The following is a description of a gene set: Human Gene Set: NKX2_3_TARGET_GENES Genes containing one or more binding sites for (NKX2-3) in their promoter regions (TSS -1000,+100 bp) as identified by GTRD version 20.06 ChIP-seq harmonization. from publication Yevshin I, Sharipov R, Kolmykov S, Kondrakhin Y, Kolpakov F (PMID 30445619) species: Homo sapiens, and this is the list of marker genes: EXOSC8, IRAK4, MIR5700, ATP5F1B, IFT88, FAM187A, NPAS1, RPS18, NQO2, RPRD2, BBIP1, WDR6, RNF26, ZNF462, TPP1, PGBD4, GRHL2, RNU11, MIDEAS, SNHG17, GFM2, KIF18A, EXD1, CAB39L, ARL3, C11orf54, TMEM106C, VANGL1, NAT9, LRRC49, POU6F1, RECQL, TSPAN4, CHMP2B, IFT56, R3HDM1, HSPG2 (NCBI Gene Id 7796), TINF2, MIR5579 (microRNA 5579), ORMDL2, HMGA2, SLC3A2, COX5B, MPI, HTT, SH3PXD2A-AS1, PIM1, DDIT3, ZFAND2A, RPL15, BRD2, NRDC, GALE, RAD52, TBC1D23, YOD1, NIPSNAP2, MAP2K3, AGPAT3, PTPA, NT5DC2, PSME2, INTS2, CLDN7, ACTG1, AVEN, PNPLA8, SERINC1, PDLIM2, MRPL42, SNORA57, MTPN, EFTUD2, CALM1 (calmodulin 1), YAP1, DCTPP1, COQ8B, EIF5-DT, TMT1B (thiol methyltransferase 1B), NUDCD3, KLRG1, AK1, BTN2A2, GPRC5B, FBXO24, PPIP5K2, SCARB2, ST3GAL3, CSKMT, SEMA5A, HTRA2, OXA1L, ZNF587B (zinc finger protein 587B), SCARB1, TMEM135, DNAJB9, PAK6, ACTR3C, IK, RPL7L1, NRM, SUGP2, TAFA2, CHP1, HLA-DMA (NCBI Gene Id 3108), MIR4645, ABCC3, PPFIA3, COPS7A, BNIP1, ANAPC5, CDC42SE1, TMEM67, ADGRE2, THAP5 (THAP domain containing 5), NIF3L1, APLP1, IFT74-AS1, NR1D1 (NCBI Gene Id 9572), EPS8, RCAN3, PIH1D1, TOMM40 (NCBI Gene Id 10452), CACNA1A, THUMPD3-AS1, DUS3L, ANO6, RIC8B, LINC02369, ZBTB7C, MRPL42P1, MBD5, RNF121, LINC02345, EMC7, EML4, PLEC, NUFIP2 (NCBI Gene Id 57532), TMEM253, ARSA, ITPRID2-DT, PLXNB1, RPAIN, SNORD59A, MRPS35, APPBP2-DT, FAM43A, RAG1 (recombination activating 1), TPM1-AS, SEC31A, ASIC1, MIR6165, TP53BP1, PEX12, ANO2, GRINA, RBCK1, TBRG4, KRTAP3-1, METTL15, TTC12, NDUFA2, C11orf98, PPP1R12A, MCFD2, ENSG00000261335, RBFOX2, ALG5, RPL26L1, CNTNAP1, MMP14, VPS16, ACP2, CNOT4, CAV1, HIF1AN, ACTR3 (actin related protein 3), DPPA5 (developmental pluripotency associated 5), AUP1, EDRF1, LEKR1, CDC37, BBX, USP8, MTMR4, SNORD49B, FAM221B (family with sequence similarity 221 member B), BUD31, NKD2, MED15, WBP11, LSM1, COPZ1, LINC-ROR, SNORD27, GRHL2-DT, SP1, RAMAC, SLAIN2, PTPN23, SUB1, COX18, TMEM8B, ANTXR2, GAPDH-DT, NPHS1, USP48, QRSL1, RPL26L1-AS1, TMTC2, LRIG2-DT, GDF11, PODNL1, ZHX2, FYN, MIR1293, ZGRF1, MRPL52, USP15, MEST, CASP6, EIF2S1, SNX1, IVD, ZNF862, FRS2, NARS2, EBNA1BP2, PDCD11, RAPGEF3 (NCBI Gene Id 27105), SULT1C2P2, UBE2F-SCLY, TOMM7, RPL37, RBPMS, TBX3, CCT6A, CCDC86, RBM3, LDLR, RHBDF1, CPSF7, UMAD1, ENSG00000224090, PTPRF, HOXA10-AS, SLC39A8, UACA, RBM19, KRT8, TRIOBP, HSPE1P12, BZW1-AS1, CASC11, SARNP (SAP domain containing ribonucleoprotein), MTIF2, LNPK, PHF19, FGD6, STK36, MFSD5, SIX5, SMU1, IST1, ACADSB, ATP6V1D, PFKFB2, MRPL33, CALM2, DGKE, SLC12A6, SRCIN1, SNORD25, TIA1, RBM7, NCOR2, ORC4, NBR1, ARFGEF2, SEPHS1P7, GFAP, HILPDA-AS1, RPA3, TPM1, PPP3CA, PPCDC, ZNF546, CHCHD5, SLC7A7, PPIB (peptidylprolyl isomerase B), GON7, GABPB2, CA5BP1, CCR10, NBEAL1, THAP9-AS1 (THAP9 antisense RNA 1), IKZF5, RBM6, GLP2R, SQSTM1, RNF212B, ULK1, ORMDL3, RNF43, CNN3, CIAO2A, ENSG00000253607, ATAT1, ABCF2, ZNF107, ENSG00000232732, SDHAF2, CIMAP1B, TMIGD1, LINC01011, GTF3C6 (general transcription factor IIIC subunit 6), KALRN, YIPF3, UQCRC2, DAND5, CEP83, TFAP2A, TEFM, ADHFE1, OCIAD1, CCNB1, RSL24D1, MB, NKIRAS1, METTL16, CACNB3, ENSG00000272384, CYB5B, RNU4-2, SP2, PCLAF, BOLA1, KLHL28, PA2G4, UBE2F, RORA-AS1, SYT5, RTN4IP1, SLC25A37, SETD5, SMG7-AS1, ARHGEF16, ABCC5, HOMER2, HOXB3, EIF5, MTND5P10, LETM1, LTA4H, MYO15B, NEK4, LRCH4, VPS52, PARP14, MLF2, SRSF11, INTS4, NUP88, TNKS1BP1, EEF2, QTRT1 (queuine tRNA-ribosyltransferase catalytic subunit 1), CLCN3, PAX3, ABRACL, GDF15, NDUFB3, LTBP4, FZD3, MIR4512, GARIN5A, M6PR, ITPRID2, DDX41, ZNF219, ZNF23, GIN1, XPNPEP3, ASTN2, USH1C, ARRDC4, CCND3, SNHG29, TTC24, TUBB4B, VIPR1, ST13, MRPS35-DT, DHRS4-AS1, TIPIN, SPATA1, INO80D-AS1, LARP7, GAPDH, PPBPP1, CEP112, RNF25, FAM13A, MYO15A, LINC02901, BDNF, EIF2B1, SMIM30, GAL3ST1, EXOC3L4, TBRG1, ZNF639, TTC39A, ARHGEF2, HOXB6 (NCBI Gene Id 3216), MCMBP, MGAT1, SHMT2, KDM4A-AS1, LRFN3, PSPH (phosphoserine phosphatase), GAS5, SHOC2, EMC10, WDR12, TARS1, SEC23IP, USP53, AP2S1, TTYH3, AP3S2, STAU2, INO80B, INO80B-WBP1, PTPRO, NEURL4, DNAJC25-GNG10, PPIL3, SLC7A8, DM1-AS, SLC44A4, ZRANB3, LETMD1, ZNF442, ZBTB37, ITPRIPL1, PNPO, UBE2K, KLF6, ZNF514, PCED1A, TNS2, SMG7, ZFYVE16, RALY, RGL2, MAML3, FAM3D, SON, MZF1, BMS1, SNHG1, MSL1, VEZT, VPS33B, ELAC2, IQCB1, NUDT5, SDSL, TMEM104, ZFYVE28 (zinc finger FYVE-type containing 28), MIR4795, NFKBIB, CHMP2A, ADCK5 (NCBI Gene Id 203054), CD9 (NCBI Gene Id 928), CENPBD2P, S100A11, NSA2, DNAJC25, EPHA1, EIF3D (NCBI Gene Id 8664), FEM1A, TMEM238L (NCBI Gene Id 400573), WARS1, BCORL1, AGTRAP, XNDC1N, CALCOCO1, SRCAP, SETDB2, RNA5SP358, MBD6, MBD1, TAX1BP1-AS1, SRP68, C1R, RNU2-18P, DRC1, SPATA41, SNORD26, MIR375, PMEL, LINC02427, CAPZA2, TTL, NAMPT, RNF31, C12orf60, ABHD2, ATL2, PCM1 (pericentriolar material 1), MAP3K12, PRSS2, KIF9, LSR, ATN1, UNC45A, LINC02441, PITRM1, FCRLA, ARMC6, PUS7L, PHAF1, OXA1L-DT, NLGN1, TARBP2, INSIG2, HILPDA, TRIP4, IFT74, RAB29, RNF13, FBXO41, BZW1, CHAC1, HDAC7, TTC33, NR1H3, PFKM, PPP1R11, ZNF451, PPP1R3F (NCBI Gene Id 89801), CCDC103, RAB5B, MAP1LC3B2, TOGARAM1, TP53I3